The following is a description of a gene set: Human Gene Set: HP_ADENOMATOUS_COLONIC_POLYPOSIS Adenomatous colonic polyposis Presence of multiple adenomatous polyps in the colon. studied in species Homo sapiens, and this is the list of marker genes: POLE, NTHL1, ENG, MUTYH, BMPR1A, RNF43, EPCAM, AXIN2, MSH3, SMAD4, PTEN, POLD1, GREM1, APC, MBD4, MLH1, PMS2